The following is a description of a gene set: studied in species Homo sapiens ADP signalling through P2Y purinoceptor 1 Human Gene Set: REACTOME_ADP_SIGNALLING_THROUGH_P2Y_PURINOCEPTOR_1, and this is the list of marker genes: GNGT2, SRC, GNB2, GNB1, GNB3, GNG11, GNAQ (NCBI Gene Id 2776), GNA14, GNG12, GNG3, GNB5, GNG8, MAPK14, GNG13, GNG7, GNA15, GNG4, GNB4, PLA2G4A, GNGT1, GNG2, GNG5, GNG10, GNA11, P2RY1